The following is a description of a gene set: from publication Nakaya HI, Wrammert J, Lee EK, Racioppi L, Marie-Kunze S, Haining WN, Means AR, Kasturi SP, Khan N, Li GM, McCausland M, Kanchan V, Kokko KE, Li S, Elbein R, Mehta AK, Aderem A, Subbarao K, Ahmed R, Pulendran B (PMID 21743478) species: Homo sapiens Human Gene Set: GSE29618_BCELL_VS_MONOCYTE_DAY7_FLU_VACCINE_DN Genes down-regulated in comparison of B cells from influenza vaccinee at day 7 versus monocytes from influenza vaccinee at day 7. Systems vaccinology has emerged as an interdisciplinary field that combines systems wide measurements and network and predictive modeling applied to vaccinology. Here we used the systems vaccinology approach to study the molecular mechanisms underlying th, and this is the list of marker genes: SLC30A1, EXT1, SIGLEC9, QPCT, SLC36A1, ADGRE2, NACC2, ARHGEF10L, RNASE2, ADAM9, CEBPA, HCAR3, FCGRT, CREB5, GNS, OGFRL1, MCTP1 (NCBI Gene Id 79772, multiple C2 and transmembrane domain containing 1), EMILIN2, FBN2, GSTP1, TALDO1, FKBP1A, CTSD, RAB20, LST1, ATP6AP1, UBE2D1, CAMKK2, MACROH2A1, RAB32, CD86, ALDOA, REEP4, AOAH, GPX1, EVI2A, NFIL3, KIAA0513, LEPROT, RCOR1, ULK2, GAA, IGFBP7 (insulin like growth factor binding protein 7), LIN7A, MICAL2, ARAP3, VEGFA, SCARB2, ST3GAL6, LILRA2, AHNAK, C1orf54, RRAGD, LAPTM4A, TIMP2, GNAQ, RBM47, TRIB1, MGST2 (NCBI Gene Id 4258), CTNNA1, SEMA4A, PHACTR2, C5AR1, CD302, CDC42EP3, TIAM1, CEBPD, BST1, GABARAPL1, VIM, NPL, HMOX1, CTBP2, CLEC4A, IRAK3, PYGL, FBXL5, PGD (phosphogluconate dehydrogenase), HEXB, GRN, KLF10, LILRB3, ALDH2, HBEGF, IL17RA, CDC42EP4, DAPK1, CSF2RA, PILRA, CYFIP1, HDAC4, MYO1F, TNFRSF1B, RXRA, IL1RN, BHLHE40 (basic helix-loop-helix family member e40), FPR1, PLXND1, SIRPB1, ALDH3B1, TBXAS1, HDGF, MSRB1, EIF4A1, ID2, LRPAP1, ICAM1, MPP1, LMNA, PLAUR, CD163, RAB27A, FZD1, IMPA2 (inositol monophosphatase 2), ENO1, SORT1, SULT1A2, SLC31A2, NAGA, NDFIP1, PSTPIP1, CPPED1, LGALS2, CREG1, APOBR, ARRB1, STX11, CPD, S100A12, PKM, RTN1, HPSE, CD63, MIR22HG, TKT, OTULINL, TREM1, MCL1, VPS37C, ERMAP, LAMP2, GASK1B, SMARCD3, RGS10, PCSK5, CST3, UPP1, SLCO3A1, ZYX, ARHGEF40, ZDHHC7, CSF1R, MID1IP1, ZNF467, SDCBP, AMPD2, GLA, RNF130, NLRP3, SERINC5, GNA15, GABARAP, DOCK5, SIRPA, CPQ, GAS7, PSAP, FLVCR2, CD58, SULT1A1, TNFSF13, SGK1, TNFSF12 (TNF superfamily member 12), MAFB, NAMPT, FUT4, ACSL1, MAPKAPK3, AP2S1 (NCBI Gene Id 9161), SLC27A3 (solute carrier family 27 member 3), CD68, PTGER2, TYROBP, PID1, WDFY3, PXN, FTL, DUSP6, HSBP1, CD14, ATF3, CCR1, TBC1D8, RGCC, EFHD2, ITM2B, CRISPLD2 (cysteine rich secretory protein LCCL domain containing 2), CALML4, CD4, CSF3R